Given this list of marker genes PHC3, DPP8, TMX3, TRAM1, ZNF423, EPHA3, FAM241A, STAG2, SLC34A1, ESR1, LAMC1, UBQLN1, PIAS2, GRIA4, CMPK2, METTL2A, MAD2L1, TSLP, LYVE1, MB21D2, YTHDF3, CCND2, MAP3K2, MAGEB6, ELF1, ZNF451, ADAMTS18, ZNF699, SLC6A6, UBE2D3, STARD4, PDP1, SSPN, FDCSP, ZNF326, ANKRD45, PPM1A, UBR3, ZNRF2, PLA2R1, KPNA3, ROBO2, KLHL1, MICU3, MARCHF11, MCCC2, MASP1, PDE10A, RAB2A, CBR1 (carbonyl reductase 1), MBD1, KHDRBS1, SLC16A1 (solute carrier family 16 member 1), USP25, TOP1, CACNB4, NUFIP2, B3GLCT, RNF24, EIF4G2, DCN, PMAIP1, CERS6, RAD21, LRRFIP1, TBC1D8, NR1D2, STRBP, NCK1, F2RL1, KLHL32, KRT20, HOXD13, COQ7, SDHA, ZBTB20, ZFX, NNT, SH2B3, LRCH2, CAB39, FUT9, PHF20, KATNAL1, NMD3, DHX15, ADCY1, LRRC40, PTP4A1, NFYB, PTPRB, IFT80, FAM76B, WRNIP1, PTPRK, FCGR2A, OSBPL8, PGRMC1, AR, TMEM35A, STMN4 (stathmin 4), CREBZF (CREB/ATF bZIP transcription factor), QKI, METTL2B, USP44, MECP2, PCDH7, ASS1 (NCBI Gene Id 445), SRSF10, ZNF681, IQGAP2, SF3B1, PWWP2A, GOLGA6L4, PHF20L1, KCNJ3, HYCC2, KDM1B, ATP1B2, SELENOI, FEM1B, MPP7, EFCAB11, CD99, SYBU, AP3B1, TBCEL, EPB41L5, DOK5, GSPT1, AMFR, DNAJA1, ZFHX3, PPARGC1B (NCBI Gene Id 153346), ZBTB18, NEK7, GDAP1, ZNF780B, KLHL24, TMEM41B, SPRED1, ODF2L, ABHD18, SP8, SH3TC2, CHORDC1, ARHGAP17, CYP7B1, IL36B, IFI44L, KAZN, HNRNPH1, PSIP1, CASK, CREBL2, TRA2A, here is a description of the gene set: Human Gene Set: MIR4275 species: Homo sapiens Genes predicted to be targets of miRBase v22 microRNA hsa-miR-4275 in miRDB v6.0 with MirTarget v4 prediction scores > 80 (high confidence targets). from publication Chen Y, Wang X (PMID 31504780)